Given this list of marker genes M, NS, PB2, HA, PA, NP, NA, CLTA, PB1, CLTC, here is a description of the gene set: part of: Influenza Infection Reactome Pathway: Entry of Influenza Virion into Host Cell via Endocytosis studied in species Homo sapiens Virus particles bound to the cell surface can be internalized by four mechanisms. Most internalization appears to be mediated by clathrin-coated pits, but internalization via caveolae, macropinocytosis, and by non-clathrin, non-caveolae pathways has also been described for influenza viruses.